The following is a description of a gene set: Any process that stops, prevents, or reduces the frequency, rate or extent of the chemical reactions and pathways involving any hormone. Human Gene Set: GOBP_NEGATIVE_REGULATION_OF_HORMONE_METABOLIC_PROCESS studied in species Homo sapiens, and this is the list of marker genes: BMP2, ATP1A1 (NCBI Gene Id 476), DKK3, WNT4, PRMT3, PDE8B, AKR1C3, BMP5, REST